The following is a description of a gene set: Catalysis of the transfer of a nitrogenous group from one compound (donor) to another (acceptor). Mouse Gene Set: GOMF_TRANSFERASE_ACTIVITY_TRANSFERRING_NITROGENOUS_GROUPS species: Mus musculus, and this is the list of marker genes: Gpaa1 (GPI anchor attachment protein 1), Pigk, Mgat4a, Kyat1, Abat, Got1l1, Psat1, Etnppl, Oat, Kyat3, Cisd1, Gapdh, Blvrb (NCBI Gene Id 233016), Gfpt2, Gfpt1, Gpt2, Gpt, Accsl, Tgm2, Got2, Aadat, Agxt2, Bcat2, Accs, Got1, Gapdhrt2, Agxt, Amt, Gapdhrt, Phykpl, Tat, Bcat1